The following is a description of a gene set: studied in species Mus musculus This event has been computationally inferred from an event that has been demonstrated in another species.<p>The inference is based on the homology mapping from PANTHER. Briefly, reactions for which all involved PhysicalEntities (in input, output and catalyst) have a mapped orthologue/paralogue (for complexes at least 75% of components must have a mapping) are inferred to the other species. part of: NCAM signaling for neurite out-growth Reactome Pathway: NCAM1 interactions electronically inferred by orthology from the curated human pathway, and this is the list of marker genes: Col9a1, St8sia4, Col2a1 (NCBI Gene Id 12824), Col5a3, Col6a5, Col6a6, Col6a1, St8sia2, Ncam1, Col4a2